The following is a description of a gene set: Mouse Gene Set: REACTOME_SYNTHESIS_OF_UDP_N_ACETYL_GLUCOSAMINE Synthesis of UDP-N-acetyl-glucosamine species: Mus musculus, and this is the list of marker genes: Pgm3, Uap1, Gfpt2, Amdhd2, Gnpnat1, Nagk, Gfpt1, Renbp